The following is a description of a gene set: studied in species Homo sapiens A clathrin-sculpted lipid bilayer membrane-enclosed vesicle after clathrin release and containing gamma-aminobutyric acid transport vesicle. Human Gene Set: GOCC_CLATHRIN_SCULPTED_GAMMA_AMINOBUTYRIC_ACID_TRANSPORT_VESICLE, and this is the list of marker genes: VAMP2, SLC32A1, DNAJC5, HSPA8, GAD2, GAD1, RAB3A, SYT1